Given this list of marker genes Zfp462, Itga6, Atoh1, Ddx3x, Supt4a, Yy2, Csrnp1, Mrtfb, Ywhab, Actr2, Med1, Gsk3b, Foxl2, Rps6ka3, Hoxb5, Med25, Nfatc3, Crx, Med18, Myocd, Tbx5, Meox1, Acvr1, Med16, Pink1, Relb, Sox15, Taf4, Taf5, Foxa3, Rnf40, Arid3c, Trp53, Foxo1, Etv1, Hif1a, Pcbp1, Pou2af1, S1pr1, Dhx9, Klf4, Ccpg1, Fev (NCBI Gene Id 260298), Actr3, Carm1, Tead4, Etv5, Pax8, Nfia, Zscan21, Bmp2, Hmgb1, Gdnf, Hsf3, Ppard, Smarcc1, Nkx2-6, Il11, Grhl3, Lrp5, Phox2b (NCBI Gene Id 245706), Elf5, Yes1, Klf15, Tfap2a, Thrb, Bmal1, Kpna6, Tcf7l2 (transcription factor 7 like 2, T cell specific, HMG box), Bmpr1a, Creb1, E2f1, Nfix, Ifi208, Zic2, Fzd4, Nrl, Gmeb1, Csrp3, Prrx2, Zcchc12, Hes1, Eomes, Tnfrsf1a, Eif4a1, E2f8 (NCBI Gene Id 74788), Rara, Nfkbia, Hoxd13, Cela1, Arx, Irf6, Fgf2, Tlx2, Kdm4c, Nod2, Gata5, Il18, Nog, Tead2, Cavin2, Jund, Smad4 (SMAD family member 4), Ikzf4, Galr2, Foxk2, Mafa, Adrb2, Prdm5, Nr4a1, Tcea2, Pid1, Il22, Med28, Pin1, Rprd1b, Med27, Ppp2r5b, Satb2, Irf3, Fgfr1 (fibroblast growth factor receptor 1), Hax1, Zfpm1, Rps6ka1, Nfatc4, Foxh1, Mlxipl, Irf7, Tet2, Zfp750, Cebpe, Cdc5lrt5, Xbp1, Hnf1b (NCBI Gene Id 21410), Aym1 (NCBI Gene Id 503692), Nr1i3, Pwwp2b, Taf6 (TATA-box binding protein associated factor 6), Bcl2l12, Pkd2, Psmc6, Tcf20, Hipk2, Rps6ka5, Asxl1, Zeb1, Hoxa7, Epcam, Npas2, Med6, Pou1f1, Tlr7, Med19, Irf2bpl, Tal1, Ovol2, Ar, Slc38a3 (NCBI Gene Id 76257), Tfap2e, Hoxb1, Galr3, Nr2f2, Olig1, Nodal (nodal growth differentiation factor), Lmo2, Tfe3, Psmc3ip, Cdc5lrt1, Tcf4, Daxx, Grhl2, Usf2, Cdc5lrt4, Macc1, Hoxa4, Zfp64, Nos1, Exosc9, Tbk1, Lhx3, Wnt7a, Tox, Gcm2, Foxf1, Apbb2, Ifi203-ps, Hoxa1, Pck1, Cys1, Ccn1, Kdm6b, Mtf1, Pik3r1, Il25, Mbtps2, Hoxd3, Lmo3, Smarcb1, Six4, Prdm15, E2f7, Vsx2, Sox11, Mir103-1, Jak2, Arnt, Pparg, F2rl1, Cxcr3, Crebbp, Bmyc, Cdk8, Dvl2, Yap1, Cytl1 (NCBI Gene Id 231162), Zc3h12a, Ell2, Med8, Acvrl1, Eef1d, Smarca2, Pax1, Nr4a2, Map2k5, Meis2, Bhlhe22 (NCBI Gene Id 59058), Hexb, Ep300, Pitx2 (paired-like homeodomain transcription factor 2), Bmp4, Ikzf2, Arid3a, Map3k1, Crem, Hoxa13, Ctbp2, Dicer1, Hinfp, Elk4, Kdm3a, Rela, Zfp639, Lum (NCBI Gene Id 17022), Arid5a, Neurog2, Ikbkg, Txk, Mamstr, Cdkn2a, Eif4a3, Pin1rt1, Foxm1, Strn3, Egr4, P2rx2, Ppp3r1, Snip1, Il6, Hnrnpd, Prkd1, Bmal2, Osr1, Sox1, Tbp, Junb, Zfp143, Nr1h5, Pfkm, Il2, Crtc1, Nr4a3, Phip, Onecut1, Ptma, Setx, Med13, Nr1i2, Reno1, Dbp, Ash2l, Usf3, Dek, Ogg1, Crtc2, Usf1, Pax6, Pth, Ldb2, Rfxap, Ddrgk1, Hdac4, Foxd3, Ube2e1, Nr1d2, Sox3, Hmgn3, Htatip2, Nelfa, Pou3f2, Ifng, Ifi209, Fhod1 (formin homology 2 domain containing 1), Hdac1, Creb3l4, Klf5, Cnbp, Tmprss6, Hhex, Hoxc10, Wnt5a, Crebrf, Med21, Paxip1, Myf6, Kmt2d, Hdac2, Etv4, Fgf10, Foxj2, Cdx2, Tbx2, Cebpb, Zbtb38, Tunar (Tcl1 upstream neural differentiation associated RNA), Six5, Ncoa7, Apbb1, Ascl3, Jup, Zbtb49, Nkx2-1, Lmx1b, Senp2, Grin1, Prdm2, T, Nfatc1, Plag1, Il13, Fgf1, Rnasel, Hltf, Kdm6a, Xrcc6, Ifi213, Pwwp2a, Klf1, Xpa, Preb, Muc1, Sp3, Etv6, Tfdp1, Sting1, Hras, Hyal2, Kmt2a, Tnf, Ino80, Ebf2, Cited2, E4f1, Sry, Vegfa, Prdm10, Ddn, Kat2a, Cdk13, Hoxb2, Ttc5, Irf2, Fgfr2, Tfec, Rb1, Nhlh1 (nescient helix loop helix 1), Ldb1, Znhit1, Churc1, Hif3a, Tox3, Hes3, Asxl3, Rbm14, Zfhx3, Thap11, Wnt3a, Bclaf3, Rel, Ebf3, Tlr9, Nkx6-3, Ucn, Cdc5l, Etv2, Pax7, Erg, Irx3, Sall1, Ifrd1, Hoxa9, Pogz, Mapk15, Max, Bmp3, Creb5, Ppargc1b, Mrtfa, Ncl, Mcf2l, Cebpz, App, Ift74, D1Pas1, Gata3, Psip1, Prdm4, Tgfb1, Rreb1, Smarca4, Six2, Mef2b, Tfcp2, Irf4, Hnf4g, Sp7, Gli1, Ccnc, Hoxd4, Notch3, Rxrg, Csf3, Ptf1a, Myd88, Wnt2, Atf2, Arf4, Calcoco1, Hcls1, Ncbp2, Rora, Ncoa3, Notch4, Foxp3, Mecom, Med14, Cdx1, Dmrt1, Atf4, Nrf1, Eif2ak3 (NCBI Gene Id 13666), Neurod2, Ces1d, Brd4, Peg3, Fezf2, Gata2, Caprin2, Zfp42, Hmgb2, Rfx7, Gdf2, Dlx5, Nampt, Morf4l2, Tlr2, Esr2, Nufip1, Med24, Sox6, Mepce, Esr1, Id4, Irf9, Rfxank, Sohlh2, Nfkb2, Itga8, Elk1, Rnf4, Med29, Lhx2, Cdc5lrt9, Nr5a2 (NCBI Gene Id 52226), Efcab7, Ruvbl2, Ssbp4, Mir103-2, Tbx3, Prdm9, Dot1l, Ifnb1, Ago2, Mzf1, Flt3l (NCBI Gene Id 14256), Bmp6, Npas4, Smarcad1, Pou3f3, Fli1, Mllt6, Agrn, Rfx2, Eapp, Tmf1, Stat5b, Drd2, Yy1, Zbtb18, Elf3, Ahr, Spdef, Ube3a, Epas1, Foxn4 (NCBI Gene Id 243222), Elk3, Ptms, Egr1, Batf, Sp1, Ecd, Sirt2, Sbno2, Lhx4, Mef2a, Fadd, Hand2, Sall4 (spalt like transcription factor 4), Galr1, Fosl1, Med31, Pax9, Vgll2, Zfp521, Stat6, Dlx2, Nme2, P2ry1, Spib, Zmynd8, Grem1, Zfp827, Psmd9, Clock, Evx1, Ell3, Nlrp3, Gata4, Ercc6, Hsf1, Cdh13, Tbr1, Stat5a, Hes5, Tfdp2, Nfya, Glmp, Serpinf2, Pus1, Sox14, Cebpg, Kat5 (K(lysine) acetyltransferase 5), Csrnp2, Myb, Lpin3, Lef1, Vdr, Ripk1, Med26, Hlf, Zfp142, Ier2, Tbx19, Cebpd, Raf1, Dcaf6, Zfp239, Pkm, Acvr2a, Rbmxl1, Irf5, E2f2, Gmeb2, Eya1, Hdac3, Med15, Akt1, Stat2, Sub1, Foxn1, Rad54l2, Spic, Osm, Kdm1a, Nr1h4, Prl2c2, Iqce, Irf8, Hoxd8, Rorb, Mir466l, Mkrn2, Litaf, Foxp1 (NCBI Gene Id 73231), Rigi, Zfp175, Mlx, Tet3, Senp1, Taf1, Rgma, Mixl1, Zfp677, Shh, Rarg, Sox8, Thap3, Sox12, Tcf7l1, Ascl5, Nr2e3 (NCBI Gene Id 50544), Rest, Crlf3, Tcea1, Dab2, Pfn1, Pou2f2, Bptf, Arid4b, Mllt10 (NCBI Gene Id 338532), Hdgf, Pitx1, Hoxd9, Prkn, Gtf2a1, Slc30a9 (NCBI Gene Id 76440), Ddx17, Atxn1, Crtc3, Neurog3, Spx, Phox2a, Zbed4, Supt6, Lif, Trerf1 (NCBI Gene Id 224829), Creb3l3, Klf10, Stat1, Nfat5, Supt4b, Zfp24, Bach1, Nlrc5, Ihh, Tbx1, Ablim2, Usp16, Ssbp2, Hoxb4, Pou4f1, Ciita, Nfe2l1, Myt1, Anxa2, Ddit3, Drd3, Aamdc, Ncbp1, Spi1, Npm1, Taf13, Ifi207, Cd28 (NCBI Gene Id 12487), Ntf3, Med11, Rrp1b, Cnot7, Med23, Nck2, Cdc5lrt7, Meox2, Hoxa10, Foxc2, Tet1, Zfp407, Kansl3, Pax3, Tbl1xr1, Deaf1, Egr2, Camta1, Lrp6, Tfap2d, Rbpj, Il33, Ptov1, Taf9, Maml1, Klf14, Bex2, Taf7, Nkx2-5, Rnf10, Acvr1b, Gsx1, Nck1 (non-catalytic region of tyrosine kinase adaptor protein 1), Brca1, Helz2, Elf4 (E74 like ETS transcription factor 4), Pax2, Runx2, Ago1, Pitx3, Parp1, Leo1, Elf1, Hoxa2, Mecp2, Foxo4, Mesp1, Purb, Msgn1, Isl2, Hivep1, Sik2, Il23a, Mybbp1a, Ncoa1, Slc40a1, Jun, Rbpjl, Mafb, Nhlh2, Zfp819, Was, Ppp3ca (NCBI Gene Id 99901), Tcf21 (NCBI Gene Id 21412), Bhlhe23, Casz1, Supt20, Mydgf, Safb, Rfx5, Armcx3, Ccl3, Rbck1, Cdc5lrt8, Brd8, Atf1, Mesp2 (NCBI Gene Id 269949), Bclaf1, Ncoa2, Ascl2, Cx3cl1, Zglp1, Barx2, Prkd2, Ssbp3, Hnrnpk, Hoxc13, Nr1h3, Bhlha15, Pou2f3, Foxd2, Epc1, Dab2ip, Zeb2, Rapgef3, Pbx1, Pou5f1, Med7, Ifi206, Atoh7, Hoxb9, Myo1c, Gtf2f2, Akna, Med10, Ccnk, Ets2, Wnt1 (wingless-type MMTV integration site family, member 1), Baz1b, Igf2, Ehf, Skap1, Plac8, Zfp335, Gal, Zbtb17, Hdac5, Stat3, Hcfc1, Helt, Ap3b1, Inhba, Phf8, Crebzf, Pygo1, Zic3, Sox10, Smad1, Sirt1, Maml3, Igf1, Bmpr1b, Tgfb3, Atrx, Mir744, Mapk7, Prkdc, Creb3, Klf7, Gtf2i, Top2a, Gli2, Nfe2l2, Il4, Med12, Rps6ka4, E2f3, Foxj3, Ndn, Nfatc2, St18, Zbtb7b, Kat6b, Taf8, Cask, Lmo1, Wwtr1, Pf4, Nfic, Cavin4, Dmrt2, Eaf2, Larp7, Rit2, Foxa2, Barhl1, Tnfsf11, Glp1r, Stat4, Cbfb (NCBI Gene Id 12400), Tbx21, Eaf1, Srebf2, Figla, Ckap2, Ell (NCBI Gene Id 234380), Gpbp1, Hamp, Ets1, Hoxb7, Meis3, Nr2f1, Cdk7, Tfr2, Ctnnb1, Zbtb7c, Mafg, Dlx6os1, Fosb, Bmpr2, Zfat, Egr3, Btbd18, Foxa1, Hoxa5, Rbmx, Pbx3, Smarca1, Alx4, Akap8l, Zmiz1, Wasl, Zfpm2, Tcf15, Itgb1bp1, Tnip1, Klf12, Ccdc62, Nkx3-1, Srebf1, Ppara, Setd3, Ap3d1, Sfpq, Mga, Hnf1a (NCBI Gene Id 21405), Prrx1 (NCBI Gene Id 98443), Jmjd6, Chuk, Tnfsf8 (tumor necrosis factor (ligand) superfamily, member 8), Neurod1, Ubp1, Auts2, Pdx1, Arid4a, Alx1, Ikzf1, Six1, Nr1h2, Hoxc11, Neurod6, Wnt10b, Mapk3, Ptprn, Arnt2, Plscr1, Srf, Gsk3a, Park7, Maff, Tfap4, Ss18l1, Esrrg, Sall2, Rtraf, Cbx7, Msx1, Glis3, Trp53bp1, Notch2, Tlr4, En1, Zfp131, Lmo7, Cdc5lrt10, Pou4f2, Tsc22d1, Hoxd10, Rax, Hnrnpu, Ebf1, Hoxb3, Traf6, Hoxc4, Cdc73, Cd81, Atmin, Slc11a1, Tcf12, Chchd2-ps, Triap1, Glis1 (NCBI Gene Id 230587), Rfx6, Camk1, Foxr1, Adcyap1, Med22, Runx1 (runt related transcription factor 1), Gper1, Sox30, Zmiz2, Neurod4, Ddx41, Ascl1 (NCBI Gene Id 17172), Pou2f1, Arid2, Myt1l, Irf1, Osr2, Nfkb1, Cand1, Barhl2, Igbp1, Taf3 (TATA-box binding protein associated factor 3), Ifi214, Sox7, Bcl9l, Twist1, Arrb1, Ezh1, Fubp3, Hand1, Gabpa, Mef2c, Plagl1, Zscan2, Sox9, Nr3c2, Otx2, Thra, Fosl2, Dmtf1, Ccnt1, Ablim1, Foxj1, Pcbp2, Gtf2a2, Gata1, Myog, Arid3b, Rgcc, Zfp263, Neurog1, Prpf6, Ebf4, Agap2 (NCBI Gene Id 216439), Wbp2, Aire, Tlr3, Atf6, Ybx1, Ankrd23, Jpx, Mitf, Dll1, Npnt, Hes6 (hairy and enhancer of split 6), Nfkbiz, Zfp292, Klf13, Notch1, Dvl3, Zfp395, Sox2, Dhx36, Slc9a1, En2, Irx6, Pomc, Zfp148, Mical2, Tef, Rfx4, Maml2, Egfr, Creb3l1, Setd4, Cdc5lrt6, Chd8, Smad5, Hivep2, Sertad1, Cdk12, Ash1l, Smarca5, Cops5, Tead1, Tnip2, Men1, Sox4 (NCBI Gene Id 20677), Zfp593, Chd6, Edn1, Foxf2, Myf5, S100a10, Zic1, Sfrp2, Hey2, Bmp5, Zfp384, Cited1, Npat, Zbed3, Atf1-ps, Akt2, Ctcfl, Bcl9, Ercc1, Gtf2f1, Sgsm1, Dlx1, Abra, Wwp2, Hey1, Nipbl, Snw1 (NCBI Gene Id 66354), Nucks1, Mycn, Chp2, Smo, Abhd14b (NCBI Gene Id 76491), Onecut2, Mmp12, Ppp1r12a, Carf, Atf7, Pgr, Tcerg1, Fbln5, Gcm1, Tbl1x, Fstl3, Med30, Foxo3, Spag8, Gabpb2, Maf, Sp100, Zfp758, Nfib, Klf9, Ptbp1, Lpin1, Tcf3, Prop1, Il17f, Sox17, Atoh8, Scx, Mybl2, Bmp7, Mavs, Mapkapk5, Atxn7, Nkx2-2, Nr5a1, Il10, Tbx20, Stk16, Myod1, Mir466d, Chd7, Il17a, Gata6, Nfyb, Zfp715, Jag1, Lmo4, Prox1, Tlx1, Tead3, Pax5, Grhl1, Cenpk, Smad2, Nkrf, Ss18, Fzd5, Gps2 (G protein pathway suppressor 2), Mysm1, Per1, Ctcf, Ccnt2, Pkp1, Larp7-ps, Egln1, Ahi1, Paxbp1, Rnf20 (ring finger protein 20), Kmt2c, Ier5, Nr6a1, Hmga1 (high mobility group AT-hook 1), Zfp212, Taf12, Dlx3, Wt1, Mndal, Rfx3, Ikzf3, Taf4b, Ndp, Il1a, Taf10, Fos, Ppargc1a, Tfeb, Ppp2r5d, Foxi1, Otx1, Sox18, Zfx, Lpin2, Mc1r, H2az1, Bloc1s2, Atm, Kat2b, Mta2, Cdk9, Olig2, Nr2e1, Akirin2, Nkx2-9, Onecut3, Med12l, Pou3f1, Ddx21, Glis2, Cripto, Atf3, Nr3c1, Actn4, Isl1, Myc, Dvl1, Rhox5, Mkx, Klf6, Sox21, Ncoa6, Pelp1, Tox2, Tex24, Taf11, Maz, Nanog, Bcl3, Med4, Meis1, Atf6b, Mettl23 (NCBI Gene Id 76492), Fhl5, Coq7, Mapk14, Ablim3 (actin binding LIM protein family, member 3), Nelfe, Prdm16, Nobox, Camta2, Mycs, Bcl11b, Plagl2, Gabpb1, Csrnp3, Smyd3, Med9, Map2k1, Six3, Cebpa, Cir1, Nr2c2, Il1b, Gli3, Tfap2b, Fgf4, Apex1, Mir143, Stra8, Mospd1, Nr1d1, Sohlh1, Zfp711, Mef2d, Gbx2, Bcas3, Tnks, Kat7, Mlxip, Hjv, Med17 (mediator complex subunit 17), Esrra, Chchd2, Pknox1, Mybl1 (myeloblastosis oncogene-like 1), Vezf1, Med20, Thrap3, Heyl, Sumo2, Pprc1, Pkd1, Ikbkb (inhibitor of kappaB kinase beta), Taf2, Ctr9, Pou4f3, Hsf2 (heat shock factor 2), Mcrs1, Ogt, Pik3r2 (phosphoinositide-3-kinase regulatory subunit 2), Kat8, Il4i1, Tbx6, Utf1, Eng, Dcn, Zfp219, Sf3b1, Ppp3cb, Nfatc2ip, Wwox, Pagr1a, Smad3, Lmx1a, Zfp523, Creb3l2, E2f4, Cdon, Atf5, Cdk5rap3, Hmga2, Zfp410, Mcidas, Fiz1, Klf2, Rxra, Ski, Rhoq, Paf1, Supt5, Nfyc, Pcgf5, Akirin1, Esrrb, Brd3, Foxd1, Asxl2, Jak3 (NCBI Gene Id 16453), Rbm15, Olig3, Rxrb, Cd40, Hnf4a, Ifi203, Bsx, Spz1, Cdx4, Trp63 (NCBI Gene Id 22061), Trp73, Nkx2-3, Met, Pbx2, Tfap2c, Zfp646, Tsc2, Nrip1, Rarb, Foxc1, Arhgef2, Zfp609, here is a description of the gene set: Mouse Gene Set: GOBP_POSITIVE_REGULATION_OF_TRANSCRIPTION_BY_RNA_POLYMERASE_II studied in species Mus musculus Any process that activates or increases the frequency, rate or extent of transcription from an RNA polymerase II promoter.